The following is a description of a gene set: species: Homo sapiens Human Gene Set: REACTOME_KERATAN_SULFATE_DEGRADATION Keratan sulfate degradation, and this is the list of marker genes: HEXA, LUM (lumican), FMOD, HEXB, GLB1L3, PRELP, GNS, KERA, ACAN, GLB1L, GLB1L2, GLB1, OGN, GALNS, OMD